The following is a description of a gene set: studied in species Homo sapiens In approximately 70% of patients with hepatocellular carcinoma (HCC) treated by resection or ablation, disease recurs within 5 years. Although gene expression signatures have been associated with outcome, there is no method to predict recurrence based on combined clinical, pathology, and genomic data (from tumor and cirrhotic tissue). We evaluated gene expression signatures associated with outcome in a large cohort of patients with early stage (Barcelona-Clinic Liver Cancer 0/A), single-nodule HCC and heterogeneity of signatures within tumor tissues. Genes over-expressed in stem cell-like cholangiocellular carcinoma. Human Gene Set: OISHI_CHOLANGIOMA_STEM_CELL_LIKE_UP from publication Villanueva A, Hoshida Y, Battiston C, Tovar V, Sia D, Alsinet C, Cornella H, Liberzon A, Kobayashi M, Kumada H, Thung SN, Bruix J, Newell P, April C, Fan JB, Roayaie S, Mazzaferro V, Schwartz ME, Llovet JM (PMID 21320499), and this is the list of marker genes: PBX3, ZNF562, EIF4ENIF1, ACO2, AGT, TMEM209, H3C6, RAB3GAP2, TFB2M, GPR137B, AAK1, THAP1, TOMM22, ZNF623, PPARGC1A, ICE1, SRP9, MED31, HOOK1, ZNF451, XPNPEP3, IMPACT, SCYL3, GGPS1, SFT2D2, RNF130, IL11RA, SAYSD1, FRMD4A, SDHC, KCTD3, ZNF749, FBXO9, NDUFA10, LARS1, RRP15, SLC6A16 (NCBI Gene Id 95514), TRAPPC4, PREPL, FXR2, NDUFA2, PRCC, CSNK2A1, ZNF264, ALDH3A2, SMG7, SLC30A9, KANK1 (NCBI Gene Id 23189), ELAC1, MIEF1, ZNF669, ZNF587, PTS, CRP, MED7, GMNN, DEDD, FBXO17, GALNT11, SLC13A1, UTP25, HKDC1, SMAD2, YIPF3, ZNF322, IL17RB, RO60, ECD, ZNF45, CUL5, OGFOD1, ZNF134, CRYZ, POGZ, DUSP3, CHML, TUT4, YTHDC2, PPP2R3A, MKKS, WARS2, ZNF177, TOM1L2, POGK, EHMT2, SMG5, PIGC, EFCAB2, RNF14, CBLL1, GOT1, RCOR3, DEPDC5 (NCBI Gene Id 9681), VCPIP1, ZNF432, MCCC1, SDHD, METTL18, SNRPE, SCTR, NAXE, TRIM52, SMIM7, RNF5, GEMIN4, YPEL1 (NCBI Gene Id 94021), PDGFD, CLASP1, HNRNPU, NF2, TMEM183A, HABP2, ZNF350, MPC2, LCMT2 (leucine carboxyl methyltransferase 2), ZHX3, RAB28, ITIH5, MAOB, SNRPN, IARS2, LRRC37A4P, TM4SF4, MLH3, FBXW11, PRLR, DYRK3, FASTKD5, PSMB6, FXYD2, UBAP2, CSTF1, GABBR1, MRPL35, RAB4A, ZBTB18, TBC1D8, MTR, ALCAM, SEH1L, FGF1, TAF5L, TP53, KLHL20, ZNF507, ARL17A, TRIM32, FARP1, LPGAT1, TBC1D16, PEX19, PCCA, ZNF212, MRPS16, ANKEF1, MRPL24, NRSN2, SCAMP3 (secretory carrier membrane protein 3), PCNX2, PRPF3, CRYAB, ALDH1B1, RANGAP1, RBM34, PARP1, PPOX, PPM1B, TIMM44, SPTBN5, SLC22A5, EVC, MRM3, SCNM1, CAMSAP2 (NCBI Gene Id 23271), ARMCX5, WDR26, HEATR1, IMPG2, NDUFB2, TIMM22, NDUFAF5, LBR, MEGF8, SUPV3L1, DGCR2, GON4L, ZBTB33, COG2, PMS2, TOMM20, ZNF155, WDR3, KIFAP3, TIMM23, ELK4, BCOR, PSEN2, ZSCAN9, PTPRF (NCBI Gene Id 5792), MAN2A1, AHCTF1, MRPL2, TOPORS, PATZ1, ZNF225 (zinc finger protein 225), EPRS1, PRKAA2 (protein kinase AMP-activated catalytic subunit alpha 2), TBC1D19, ZSCAN16, ABI2, TOR1AIP1, BPHL, FBXO28, MRS2, NUP133, EFCAB11, SERPINA6, ZNF124, MRPS14, GCNT4, ATP13A3, EIF2D, MTERF4, ZNF692 (zinc finger protein 692), SLC38A1, ZNF473, RABL2B, RNF19A (ring finger protein 19A, RBR E3 ubiquitin protein ligase), SPTSSA, PIAS2, PROX1, DDX10, ZNF146, KLHL12, GPATCH2, MED20 (NCBI Gene Id 9477), BMPR1A, PIP5K1A, FAM53C, RBBP5, ANXA9, ZNF480, VN1R1, PGBD5, ZNF20, GPR75, ZNF232, CAV2, MDM4, ZNF222, POLR1C, RBM7, UCHL5, ZC3H7B, NVL, UFC1, MED17, ZBTB20, MRPL46, DHX9, CDC42EP1, ZNF224, AQP4, SUCO, POLR2F, TRIM26, ASB1, NNT, PCBD1, RRH, FGFR4 (fibroblast growth factor receptor 4), ABCC4, VPS72, NOL12, ZNF550, C6orf62, CERS2, NDUFAF1, NDUFS2, PRR3, DRC3, SRPK2, TCTA, ZNF226, TRMT1L (NCBI Gene Id 81627), UBAP2L, ZKSCAN5, ODR4, LANCL1, RPS6KC1 (ribosomal protein S6 kinase C1), DLAT, COX10, DGCR5, ENAH, GCC1, KLHL22, SLC25A23, NUP153, SPP1, MZF1, TGFB2, SETDB1, APCS, MORC2, PDZK1, AATF, TMCO1, ZNF304, SSR2, PSG4, FH, TIMM8A, BPGM, APTX, ZNF202, MRPS30, CREB5, NECTIN3, WDR12, ITPA, LAMP2, AASDHPPT, ATP5MG, PMM1, CTPS1, INTS7, ANGEL2, BYSL, PUS3, DNPH1, ZSCAN2 (zinc finger and SCAN domain containing 2), ZNF672, GAL3ST1, CRK, HNF1B, RMND5B, NFS1, PHGDH, SYNGR1, ONECUT1, NUDCD3 (NudC domain containing 3), TOP3B, BCS1L, SLC25A44, TIMM17A, ARHGAP29